Given this list of marker genes GH1, STAT6, STAT5A, TYK2, JAK3, LYN, PTPN1, STAT5B, JAK1, STAT3, JAK2, here is a description of the gene set: The process in which STAT proteins (Signal Transducers and Activators of Transcription) are activated by members of the JAK (janus activated kinase) family of tyrosine kinases, following the binding of physiological ligands to the growth hormone receptor. Once activated, STATs dimerize and translocate to the nucleus and modulate the expression of target genes. species: Homo sapiens Human Gene Set: GOBP_GROWTH_HORMONE_RECEPTOR_SIGNALING_PATHWAY_VIA_JAK_STAT